Given this list of marker genes ALPI, WAS (WASP actin nucleation promoting factor), L1CAM, CLCN7, DRG2, PDE6B, MPP2, RABGGTA, AANAT, TLN2, FANCC, EFNA3, PSG7, BCAT2, VPS72, PLK1, CSN3, RING1, GSTZ1, PRKCG, DHPS, NEFL, LYST, MYBPC2, SLC2A4, HMGA2, TFE3, CCR9, MAP1A, GCGR, ERV3-1, RENBP, GPER1, FEV, KRT32, CYP2F1, AQP2, COL14A1, SIRPB1, KRT6C, TH, MADD, PAK1, GPR31, GRM4, AVPR1B, DGCR6, TRIP13, TMEM106A, TTF1, SCNN1G, ABCC1, PRKAG1, DRD1, ELK1, MIEF1, SMARCD1, HIVEP1, PMS2P11, CHERP, CLCN1 (chloride voltage-gated channel 1), ODF1 (outer dense fiber of sperm tails 1), ADRB3, here is a description of the gene set: Neighborhood of PRKCG studied in species Homo sapiens Human Gene Set: GCM_PRKCG Neighborhood of PRKCG protein kinase C, gamma in the GCM expression compendium